Given this list of marker genes L1CAM, BACH1, LGALS8, CTSH, SETD6, NAPG, ABHD4, ANAPC16, AFDN, IFIT1, TYROBP, ASB2, IL21R, CHD9, HDAC10, MAN2A2, CCDC112, PRCP, CEBPD, CTNND2, SLC44A1, EEF2K, PARP14, RAP2B, MAPK11, SLC25A53, NXPE4, PRKCB, BCL3, SESN1, PXYLP1, ARHGDIB, RBM43, MADD, RAPGEF1, RBM38, CD300A, RSAD2, SASH3, RNASEL, DMRTB1, PILRB, TNFSF8, SLC29A1, DNAJC22, TEX9, CADM3, PIK3CG, CDH17, GPR183, AEBP2, BCAS1, IGLC7, CERS6, NRBF2, NCALD, E2F2, IGSF6, RARG, ZBTB18, DDHD1, SLC38A2, TMEM74, ITPR3 (NCBI Gene Id 3710), C1GALT1, STK4, EIF4B (NCBI Gene Id 55378), SPNS3 (SPNS lysolipid transporter 3, sphingosine-1-phosphate (putative)), CYBA (cytochrome b-245 alpha chain), FLVCR1, CSGALNACT2, RTN1, SASH1, PNPO (pyridoxamine 5'-phosphate oxidase), SSH2, RAB37, CDCP1, NFAM1, INPP5F, USP18, SERPINI1, DDIT4, COQ8A, DOCK10, B4GALT6, EPB41L3, PGLYRP2, CHST10, SUPT4H1, FCRL1 (NCBI Gene Id 115350), SUCNR1, MAP3K5, KCNK6, MCEMP1, GALNT1, DGKD, MYO1E, SHISA5, PGLYRP1, CASP1, ZMAT1, RIPK2, ZBP1, SIX3, EVI5, GSN, PTPN6, SIDT2, CHKA, IL7R, DDR1, CLPTM1, SPIRE1, UBN1, NR1D2, CD302, PTPN1, SLC12A2, DAPP1 (NCBI Gene Id 27071), OGFRL1, FRMD5, MYG1, B4GALNT1, CSF1R, CD47, PTP4A3, GPR155, TMED8, TNFRSF13B, DAB2IP, CEP63, S100A6, FILIP1L, CDC42EP2, THUMPD2, MDH2, FASLG, JMJD1C, SLC44A2, CASS4, STARD9, MSN, CNOT6L, RPLP2, RAD51C, IFFO1, PTPRO, ABCA7, PTCH1, AKAP13, PDE4DIP, RGS3, RMND5B, CYRIA, CTSZ (cathepsin Z), RASAL2, BCL11A, GRAP, IL31RA, NRROS, CDC37L1, ITGB3, PTPN12, PYGL, CTSD (NCBI Gene Id 196214), HAUS8, IL6R, ARHGAP6, ACKR1, KRT80, OAS1, HOXC4, DSCAM, POT1, NHERF1, PANX1, CNPY4, HLA-DOA, JAK3, TSPAN9, ACOT7, MYCBP2, TMEM131L, SMAD1, SIX5, ARSK, CD5, TMEM71, NAPSA, SLC25A37 (NCBI Gene Id 55881), POU2F2, XPO4, DBP, LCP2, CTSS, RGS12, HSD17B4, MMP9, IFT140, LIME1, here is a description of the gene set: Genes down-regulated in B16 melanoma (day 3): untreated versus adoptive transfer therapy. species: Homo sapiens Myeloid-derived cells comprising the tumor stroma represent a heterogeneous population of cells critical to the structure, function and growth of established cancers. We have recently found that engineering tumor-specific CD8+ T cells to secrete IL-12 (IL-12TD) can lead to striking improvements in T-cell activity against established melanomas in murine models. Surprisingly, IL-12-dependent enhancement of CD8+ T-cell anti-tumor function did not occur through direct ligation of receptors on lymphocytes or NK cells. Instead, IL-12 sensitized host bone marrow-derived tumor-stromal cells, partly through interferon-gamma, to indirectly enhance the effects of adoptively-transferred T cells. Direct presentation of antigen by tumor was not necessary, but MHC class I expression on endogenous cells was essential for IL-12 mediated anti-tumor enhancements. Upon successful treatment with IL-12TD cells, we observed the selective elimination of tumor-infiltrating CD11b+ F4/80+ macrophages, CD11b+/ClassII+/CD11c+ dendritic cells and CD11b+/Ly6C+/Ly6G- but not CD11b+/Ly6C+/Ly6G+ myeloid-derived suppressor cells within regressing lesions. These results are consistent with a model whereby IL-12 triggers the maturation of myeloid-derived cells into competent antigen cross-presenting cells. Licensed recognition of these antigens by effector T cells may in turn trigger the collapse of the tumor stroma and aid in the regression of large vascularized lesions. Human Gene Set: GSE29164_UNTREATED_VS_CD8_TCELL_TREATED_MELANOMA_DAY3_DN from publication Kerkar SP, Goldszmid RS, Muranski P, Chinnasamy D, Yu Z, Reger RN, Leonardi AJ, Morgan RA, Wang E, Marincola FM, Trinchieri G, Rosenberg SA, Restifo NP (PMID 22056381)